Given this list of marker genes Slc3a2, Plaat1, Slc2a6, Atp6v1a, Ctsz (NCBI Gene Id 99199), Nkg7, Slc66a1, Rufy4, Insr, Nprl3, App, Myo7a, Chit1, Plekhm2, Myo5a (NCBI Gene Id 57374), Smpd1, Ulk3, Rnf152, Lrba, Cln5, Abcb9, Trim21, Calr, Slc36a3, Tmem9, Pde1c, Cybrd1, Slc37a3, Slc38a7, Trp53inp2, Rab23, Gns, Ncoa4, Ctsm, Ccz1, Naga, Kcmf1, Wdr45b, H2-D1, Mitf, H2-Eb1 (NCBI Gene Id 406211), Flcn, Wdr59 (NCBI Gene Id 319481), Sqstm1 (NCBI Gene Id 18412), Litaf, Rragd, Il1b (NCBI Gene Id 16176), Vps4a, Rnase6, Hgs, Stx3, H2-Ea, Marchf9, Rab24, Tsc2, Mtor, Pip4k2c, Ap1s2, Cdip1, Plbd1, Chmp1b, Gm1110, Litafd, Epg5, Cd68, Klhl22, Spns1, Tax1bp1, Hspa8 (heat shock protein 8), Ctso, Borcs5, Htt, Cts6, Anxa2, Slc22a17, Atp6ap2, Slc3a1, Cxcr4, H2-DMb1, Ace, Tmem230, Chmp4b, Optn, Manba, Sppl2c (NCBI Gene Id 278327), Cd300ld3, Lamp2, Dnm1l, Mst1, Abcd1, Col6a1, Ifitm1, Tpsab1, Rilp, Rab29, Ubxn6, Gba1, Glb1l3, Tmem165, Srpx, Prcp, Ambra1, Vps26a, Slc30a4, Atp6v1d, Slc35f6, Slc39a8, Slc30a3, Acp5, Slc36a2, Mlc1, Ctns, Cdc42, Slc2a13, Atp13a2, Wdr48 (NCBI Gene Id 67561), Map1lc3a, Mt1, Arrdc3, Thbd, Ppt1, Atp6v0b, Sod1, Abca5, Ap5m1, Cpq, Dram1 (NCBI Gene Id 71712), Galns, Arl8b, Tab2 (NCBI Gene Id 68652), Ctss, Chmp1a, Rab10, Clcn4, Glb1l2, Pgap6, Zfyve1, Lgmn, Tial1, Tbc1d12 (NCBI Gene Id 209478), Ctsll3, Vti1a, Vamp2, Irgq, Ldlr, Gzmf, Lipa, Tinagl1, Defa38, Capn2, H2-M10.2, Vopp1, Atp6v1c2, Cst7, Atp6v0a4, Ramp3, Rnf19b, Clcn7, Entpd4, Zfyve26, Ulk1, Map1lc3b, Creg1, Rab27a, Ffar4, Ostm1, Rab2b, Scarb2, Mapk15, Ifi30, Tmem9b, Ctsd, Tm9sf1, Stx17, Slc29a3, Abca2, Pdgfrb, Fnbp1, Mefv, Tasl, Laptm4a, Trp53inp1, Lrrc8a, Tcirg1, Ctsj, Vps11, Rab39, Atp6v1h, Tlr9, Vmp1, Rab12, Gga3, Prss57, Chmp3, Ticam1, Rictor, Hyal4, Atp6v1b1, Arsa, Tmbim1, Prf1, Wipi1, Sar1b, Gimap5, Slc48a1, Gfap, Cd164, Pik3c3, Gramd1a, Mpo (NCBI Gene Id 268460), Gusb, 4930486L24Rik, Plaat3, Mst1r, Tmem97, Tmem25, Sgsh, H2-K1, Sesn2, Ctbs, Tmem138, Rab2a, Bace1, Sar1a, Plbd2, Depdc5, Src, Hgsnat, Cd1d2, Zp3r (zona pellucida 3 receptor), Rab3gap2, Traf3ip3, Rab3a, Irgm2, Lamtor5, Anxa6, Dnase2a, Borcs7, Grn, H2-T22, Cts8, Uvrag, Neu4, Nbr1, Mmd, Mlst8, Tmem192, Mcoln1, Trip10, Sort1, Dram2 (DNA-damage regulated autophagy modulator 2), Gabarapl2 (NCBI Gene Id 93739), Adam8, Rpn2, Syt7, Ctsr, Srgn, Mtmr2, H2-Q7, Chmp4c, Vps33b, Trim23, Dld, P2rx4, Atg9b, Mgat3, Cd63, Tlr8, Ear14, Sbf2, Ifitm3, Spaar, Calcoco2, Unc93b1, Becn1, Snx6, Ctsw, Slc36a1, Wwox, Chmp5, Mreg, Hexa, Ube2a, Vps13b, Sppl2a, Deptor, Atp6v1g1, Ap1s3, Tbc1d5, Vps35, C9orf72, Atp10b, Slc15a4, Rab7b, Slc46a3, Bbc3, Slc15a3, Slc12a9, Cyb561a3, Pld3, Aup1, Vps39, Cit, Naaa, Rnaset2b, Chmp7, Wdr81, Cts7, Syt11, Dbndd2, H2-DMa, Itm2c, Cd34, Glb1, Ctsk, Kcnq1, Arsg, Ctsc (cathepsin C), H2-Q6, Fuca2, Bloc1s2, Gabarapl1, Atxn3, Entpd4b, AY761185, Aga, Ank3, Crhbp, Tlr7, Pfpl, Slc38a9, Vti1b, Atraid, Anxa1, Atg16l1, Hps6, Rnaset2a, Tfeb (NCBI Gene Id 21425), Tspan1, Pld4, Vma21, Rraga, Tmem163, Ap5s1, Slc26a11, Doc2a, Chmp6, Pip4k2a, H2-M10.6, Tmem74, Asah1, Rnf167, Ifitm2, Pla2g10, H2-M11, Mcoln3 (mucolipin 3), Snx14, Rab9b, Nprl2, Ulk2, Kptn, Sidt2, Marchf2, Pcsk9, Slc30a2, H2-M5, Tm4sf5, Tex264, H2-Q10, Ifnar1, Gzmc, Slc11a2, Tnfaip8l2, Lrrc8e, Dpp7, Chmp1b2, Defa43, Chid1, Jmy, Rb1cc1, Pik3r4, Chmp2b, Spaca3, Arhgef7, H2-Q1, Abcd4, Vps18, Serpinb1a, Trim32 (tripartite motif-containing 32), Cryab, Chmp2a, Spata31, Psapl1, Washc1, Ubqln4, Neu3, Ncstn, Rps6kc1, Klc2, Defa20, Atg16l2, Slc49a4, Hyal1, Cln3, Stx4a (NCBI Gene Id 20909), H2-Oa, Tfe3, Stx8 (syntaxin 8), Fnip2, Rragb, Neu2, Atp6v1f, Lamtor2, Nrbf2, Npc1, Znrf2, Gzmb, Vac14, Kif5b, Tmem199, Pla2g4e, Plekhf1, Acr, Dapk2, Vamp8 (vesicle-associated membrane protein 8), H2-Aa, Atg9a, Npc2, Cltc, Glmp, Ap1g1, Slc17a9, Hyal3, Plekhm1, Spaca7, Man2b2, Prkcd, Lrrk2, Arsk (arylsulfatase K), Lamp1, Gnptg, Anxa11, Mapkap1, Psap, Nsg1, Wipi2, Cubn, Naglu, Unc13d, Vps41, Vps33a, Rheb, Slc7a5, Hpse, Ttc3 (NCBI Gene Id 70444), Osbpl7, Mcoln2, Slc31a2, Ftl1, Ppt2, Atg5, Treml4, Prmt1, Epdr1, Cylc1, Tpcn1, Akr1b1 (NCBI Gene Id 11677), Arsb, Galc, Rmc1, Tmem175, Tecpr1, Defa39, Snx1, Borcs8, Trim17, Ocln, Clcn3, Tpp1, Ank2, Tmem79, Rab14, Oca2, Gaa, Tinag, Gla, Abhd6 (abhydrolase domain containing 6, NCBI Gene Id 98228), Sidt1, Idua, Gpr137, Ctsl, Fnip1, Ctsf, Rnf183, Ccdc115, Mpeg1, Fgfr3, Rab9, Acp2, Marchf3, Dnase2b, Slc39a14, Marchf8, Rubcn, Tpcn2 (two pore segment channel 2), Bcl10, Gpr143, Capn1, Has2, Clnk, Ctsg, Ap1b1, Fcmr, Clec16a, Mios (NCBI Gene Id 97312), Cd1d1, Hap1, Gabarap, Ankrd27, Arl8a, Lmbrd1, Slc36a4, Ubqln2, Fth1, Fasl, Psen1, Bloc1s1, Defa32, Cd74, H2-Q2, Pcyox1, Atp6v1e1 (ATPase, H+ transporting, lysosomal V1 subunit E1), Prss16, Ubqln1, Hck, Borcs6, Lamtor3 (NCBI Gene Id 99927), Minar2, Vps13a, Ids, Gzme, Tsc1, Siae, Atg4b, Mfsd8, Tmem63a, Ctsh, Irgm1, Atg14, Tmem203, Lamp5, Nos1, Ap1s1, Ap1m1, Rab8a, Laptm4b, Pla2g15, Meak7, Prtn3, Cxcr2, Mfsd1, H2-Ab1, Atp6v1b2, Snx16, Atp6v0d2, Atp6v1g3, Sting1, Sh3glb1, Tmem150c, H2-Ob, Atp6v1c1, Uba1, Tm6sf1, Calcrl, Ap5z1, Marchf1, Rnf13, Stx7, Ifitm7, Kxd1, Snx2, Rragc, Hyal2, Hps4, Atp6v1g2, Igtp, Bri3, Acp3, Gpc3, Rptor (NCBI Gene Id 74370), Napsa, Sphk2 (NCBI Gene Id 97350), Gpr137c, Neu1, H2-M2, Slc9b2, Vps16, Lamtor1, Rubcnl, Szt2 (NCBI Gene Id 230676), Snapin, Tmem106b (NCBI Gene Id 76086), Gpr155, Stxbp2, Gzmg, Tbc1d7, Ggh, Ada, Gzmd, Tbc1d14, Itfg2, Rnasek, Atp6v0d1, H2-M10.1, Nsg2, H2-DMb2, Mfsd12, Eva1a, Tmem45b, Lamp3 (NCBI Gene Id 239739), Shkbp1, Rab7 (NCBI Gene Id 19349), Abca3, Spag9, Kics2, Sec13, Cyb561, Wdfy3, Man2b1, H2-Eb2, Gzmn (granzyme N), Rab38, Prdx6, Elapor1, Pip4p2, B2m, Hexb, Lars1, Pip4k2b, Peg3, Znrf1, Sppl2b, Abcb6, Gpr137b, Hsp90ab1, Wdr83, Cts3, Fyco1, Slc17a5, Slc11a1, Siglecf, Ctsb, Slco2a1, Laptm5, Pip4p1, Snap29, Akr1b10, Kif2a, Atg13, Vps13c, Tbc1d17 (TBC1 domain family, member 17), Tmem150b, Vps36, Ctsa, Il4i1, Sftpb, Atg12, Grin2b, H2-M10.4, Fuca1, Slc7a14, Scarb1, BC051665, Atp6v0c, Tbc1d25, Dtx3l, Prkd1, Ctsq, Glb1l, Wdr24, Akr1b7 (aldo-keto reductase family 1, member B7), Pla2g5, Tmem59, Trpv3, Sult1c2, Snap23, Tnfaip3, Seh1l, Akr1b8, Defa42, Acp4, Nppa, Lamtor4, M6pr, Atp6v0e2, Gm2a, Atp6v0a1, Trim29, Trpm2, Atp6v0a2, here is a description of the gene set: Mouse Gene Set: GOCC_VACUOLE A closed structure, found only in eukaryotic cells, that is completely surrounded by unit membrane and contains liquid material. Cells contain one or several vacuoles, that may have different functions from each other. Vacuoles have a diverse array of functions. They can act as a storage organelle for nutrients or waste products, as a degradative compartment, as a cost-effective way of increasing cell size, and as a homeostatic regulator controlling both turgor pressure and pH of the cytosol. species: Mus musculus